Given this list of marker genes RHO, TRPM1, NYX, SAG, GNB3, CABP4, GPR179, CACNA2D4, CACNA1F, GRK1, GRM6, SLC24A1, LRIT3, CFAP418, GNAT1, PDE6B, here is a description of the gene set: Reduced amplitude of dark-adapted bright flash electroretinogram a-wave Human Gene Set: HP_REDUCED_AMPLITUDE_OF_DARK_ADAPTED_BRIGHT_FLASH_ELECTRORETINOGRAM_A_WAVE species: Homo sapiens An abnormal reduction in the amplitude of the a-wave.